The following is a description of a gene set: The process of regulating the proliferation and elimination of cells of the immune system such that the total number of cells of a particular cell type within a whole or part of an organism is stable over time in the absence of an outside stimulus. Human Gene Set: GOBP_LEUKOCYTE_HOMEOSTASIS species: Homo sapiens, and this is the list of marker genes: TSC22D3, PDE4B, TNFAIP3, BCL2, TNFSF13B, MTHFD1, TCIRG1, IL2RA, SLC7A11, CHST3, LGALS9, BAP1, SLC15A4, F2R, XKR8 (XK related 8), FLT3, LGALS2, FOXN1, PMAIP1, ITPKB, PIK3CB, ADAM17, SIT1, NKX2-3, AXL, LMO1, PPP2R1A, CASP3, NCKAP1L, RIPK3, TNFRSF13B, IL6, STAT5A, CAMLG, AKT1, GPR15LG, TNFSF14, CD74, CSF1, PPP3CB, HCAR2, RC3H1, DOCK11, PRDX2 (NCBI Gene Id 7001), IL7R, DNAJA3, LAT, HMGB1, SLC39A3, HIF1A, STAT5B, LIPA, SH2B3, PKN1, RC3H2, SLC40A1, SLC46A2 (solute carrier family 46 member 2), BCL10, JAM3, P2RX7, BAK1, GPAM, BBIP1, KITLG, CXCL6, FADD, BBS4, FOXP3, GPR174, TGFB1, ZC3H8, BTK, SOS2, PPP2R3C, JAK3, AIM2, SASH3, MEF2C, FAM3D, TRAF3IP2, CCR2, IL2, NF1, CORO1A, ANXA1, CCNB2, WDR37, MERTK, TSPAN9, FCER1G, LYN, SOS1, BCL2L11, BAX, RAG1 (NCBI Gene Id 5896), GCNT4, TGFB2, ABL1, MIF, FCAR, SKIL, ADA, MPL, IKBKG, TNFRSF17, IL20RB, PACS1, MIR17HG, SPNS2, FAS, GAPT, PPP2CA, SPTA1, PIK3CD, DOCK10, SIVA1, GPR183, SH2B2